The following is a description of a gene set: Abnormal male reproductive system physiology An abnormal functionality of the male genital system. Human Gene Set: HP_ABNORMAL_MALE_REPRODUCTIVE_SYSTEM_PHYSIOLOGY studied in species Homo sapiens, and this is the list of marker genes: BMP2, SLC29A3, MRAP (NCBI Gene Id 56246), SOX3, SPAG17, ZNF365, CFAP300, IRF4, ALMS1, HESX1, WFS1, ARL2BP, FGF8, DNAJB13, DNAI1, AKT1, MEIOB, UBAP1, RAD51C, HFE, DRC1, GBA2, CTNS, FANCE, DNAH2, MSH5, HTRA2, TTC29, NHLH2, MCM8, TSPY1, DNAAF11, KISS1, CYLC1 (NCBI Gene Id 1538), ATXN8OS, XRCC2, RSPH3, DNAH5, PROK2, CTSH, CCDC141, EIF2S3, KDM5D, NANOS1, FLRT3, TRAF7, GUCY1A1, ZFPM2, USP9Y, WEE2, FANCF, STK36, SMO, SOX9, CATSPER2, WDR11, DNAJC6, BCL10, CFAP74, FANCL, ATM, NCF1, LHCGR, RSPH4A, STK33, FKBP6, CLDN2, BRCC3, NSMF, SSX1, KISS1R, ERCC1, CFAP47, TEKT3 (tektin 3), DNAJC30, CFAP58, SNCA, POLD1, CFAP69, SPACA1, LHB, XKRY, DNAAF3, SEMA3A, CISD2, ADGRG2, DZIP1, PMFBP1, CCDC40, CFAP43, ZMYND15, GCNA, GTF2IRD2, CCDC146, ANAPC1, FANCA, CFAP410, WNT4, CFAP45, DNAH11, SMARCE1, NEK10, DHX37, ALG9, DAZ3, DNAH9, SYCP2, DNAH1, NR0B1, DNAAF2, FGFR1, SPRY4, BICC1, CATIP, HYDIN, FGFR3, GTF2IRD1, GNRH1, TEX11, FANCI, RSPH1, CHD7, SYCP3, CDKN2C, BRCA1, TMEM270, BRWD1, DAZ4, PDE11A, LRRC23, ENSG00000288330, RTN2, PDHA2, DAZ1, TEX15, IL17RD, TUBB8, SYCE1, MOG, PATL2, SPATA22, RPL10L (NCBI Gene Id 140801), NDP, MEN1, HAMP, SOHLH1, DNAAF6, MSH4, OCRL, KASH5, TTR, ZSWIM7, CFAP221, GBA1, SLX4, HNF1B, CDH23, CLIP2, RBMY1A1, PARK7, TFR2, CACNA1G, NDNF, ERCC8, PRKAR1A, POC1A, PINK1, SPAG1, FOXJ1, LRRK2, DNAJB11, NF2, DNAH7, ZMYND10, ODAD4, HSD3B2, DNAAF5, RSPH9, MOV10L1, HBB, P2RY11, AIP, POR, SUFU, FSIP2, HLA-DQB1, STAR, CT55, LIMK1, GATA4, TDRD9, IFT172, TTC21A, ABCD1, KCNU1, TERB2, FGF17, VPS13C, KIT, RPS4Y2, ANK1, LRRC56, BRDT, STX1A, ANOS1, PDGFB, ODAD2, SEPTIN12, SLC40A1, GTF2I, DBH, SLC26A8, TEX14, C14orf39, PANX1, PRKN, DNAAF1, RPGR, CEP19, CCDC39, CDC14A, SUN5, RFWD3, CATSPER1, SRY, BAZ1B, CEP112, CDY2A, FEZF1, CCDC34, HSFY1, CDKN1B, FANCD2, METTL27, PKD2, PROKR2, UCHL1, WDR19, IFT140, CFAP91, NR3C1, TAC3, HLA-DRB1, CFAP61, DAZ2, ODAD1, MC2R, STRC, MAP3K1, MAD2L2, LMNB1, PNLDC1, CNBP, PALB2, TTC12, SMARCB1, BMP6, PIGA, DNAH8, SOX10, FANCC, CFAP298, WWOX, KLHL10, SYNJ1, AR, NR5A1, TNFSF4, MECP2, UBE2T (ubiquitin conjugating enzyme E2 T), CYP17A1, TERB1, FSHB, RFC2, RAD51, CFAP65, PKD1, ELN, NNT, DNAI2, DCC, DNAH17, WT1, ARMC2, CCIN, FANCM, DNAL1, STAG3, CDY1, CFTR, BPY2, HCRT, M1AP, DNAAF4, PIK3CA, GANAB (glucosidase II alpha subunit), TACR3, STK11, CCNO, ERCC6, BLM, OFD1, VPS37D, FANCB, NME8, FBXO43, FMR1, HS6ST1, SPINK2, SPEF2, MCIDAS, AK7, TBL2, STEAP3, SACS, BUD23 (BUD23 rRNA methyltransferase and ribosome maturation factor), HEXB, PODXL, NME5, GPR101, SCP2, GALC, EIF4H, ERCC4, COQ2, AIRE, DNHD1, GNRHR, ODAD3, ALG5, CFAP251, FANCG (NCBI Gene Id 82603), DNAH10 (NCBI Gene Id 55921), CDKN1A, RNF212, BRIP1, AKAP3, BAP1, DNALI1, HJV, VAMP7, DDX3Y, DHH, VCY, BRCA2, TXNRD2, TAF4B, POLA1, GAS2L2, IFT74, ANTXR1, CDKN2B, USP26, TERT, SHOC1, DUSP6, ARMC12, CFAP70